The following is a description of a gene set: Blindness Human Gene Set: HP_BLINDNESS Blindness is the condition of lacking visual perception defined as a profound reduction in visual perception. On the 6m visual acuity scale, blindness is defined as less than 3/60. On the 20ft visual acuity scale, blindness is defined as less than 20/400. On the decimal visual acuity scale, blindness is defined as less than 0.05. Blindness is typically characterized by a visual field of no greater than 10 degrees in radius around central fixation. studied in species Homo sapiens, and this is the list of marker genes: CEP19, CEP290, HPS1, ZNF513, PDHA1, NDUFS4, NDUFA6, ZNF408 (zinc finger protein 408), BBS4, NDUFAF4, PDGFB, CAPN5, B3GALNT2, NAA10, FKTN, OPA3, AIPL1, RP1, TBC1D24, MFSD8, PPT1, HEXB (hexosaminidase subunit beta), PDE6G, FAS (NCBI Gene Id 355), GMPPB, KIF11, IDH3B, PRPS1, PIK3R2, BMP4, ATP5F1D, MT-ND3, AHI1, SLC7A14, EYS, BBIP1, CLN3 (CLN3 lysosomal/endosomal transmembrane protein, battenin), PRPF8, NDUFV2, CLRN1, BBS10, POGZ, ABCD1, ARL6, COX7B, PRCD, PDE6A, ROM1, CNGB1, FREM2, CDH23, KIF14, IL12A, AKT1, AIP, LARGE1, CREBBP, CFAP418, NEK2, IDH3A, SARDH, RBMX, SMO, MERTK, CNGA1, PEX6, TMEM216, NDUFS8, B4GAT1, CCR1, NDUFAF5, NF2, C4A, FLVCR1, TLR4, CRX, CTNS, PRPF6, RBP3, SDHAF1, TIMP3, SDCCAG8, HCCS, BEST1, GUCA1B, SREBF1, NDUFB10, NDUFAF1, PROM1, ERCC4, FZD4, CERKL, ITGA2B, TSPAN12, PLA2G6, RLBP1, GATA1, CC2D2A, TMEM126B, GP1BA, CA4 (carbonic anhydrase 4), BBS12, KLHL7, NR2E3, MEN1, NDUFB3, PCARE, KIAA1549, LRP5, GJB2, HEXA, PLOD1 (NCBI Gene Id 5351), NLRP3, LRAT, OFD1 (OFD1 centriole and centriolar satellite protein), ARNT2, MT-ATP6, PRPF4, TMEM138, GNAQ, AGBL5, TULP1, UROD, ATP5F1E, RDH12, IMPDH1, TOPORS, PRPF3, NDUFS7, PSAP, SCLT1, OAT, ASNS, NDUFAF8, BBS9, BBS1, MTR, GNAS, ALMS1, KLRC4, NDUFAF2, FBN1, RP9, IFNGR1, EIF4A2, FDXR, TNFSF11, SDHA, EIF2B1 (NCBI Gene Id 1967), UROS, IFT74, MKKS, NDUFS3, FKRP, ATOH7, USH2A, NDUFV1, HGSNAT, KIZ, HSD17B10, SMCHD1, ITGB3, IMPG2, CEP164, FAM161A, FOXRED1, TERT, ATRX, ARL3, SUFU, SMARCE1, CRB1, BCOR (NCBI Gene Id 57686), CDH3, ATXN7, NDUFS1, RGR, ATIC, ATP5MK, ACTB, STAT4, SAG, POLG, GP1BB, BTNL2, ATP1A3, IFT88, IL12A-AS1, NF1, SEMA4A, PANK2, DHDDS, BBS7, RP2, TTC8 (NCBI Gene Id 123016), PIK3CA, PRPH2, LONP1, TIMMDC1, MTRR, SCN1A, MEFV, ITGA2, MKS1, TUB, CTC1, PITX3, HLA-DRB1, UBAC2 (NCBI Gene Id 94902), SDHB, NDUFB11, SPATA7, NUBPL, MT-ATP8, ATPAF2 (ATP synthase mitochondrial F1 complex assembly factor 2), PQBP1, NDUFB9, NDUFS2, HLA-B, NDUFAF3, NSMCE2 (NSE2 (MMS21) homolog, SMC5-SMC6 complex SUMO ligase), CLCN7, IFT172 (intraflagellar transport 172), RPE65, BBS5, RPGR, IMPG1, ERAP1, CYP4V2, NRL, ABCA4, NDE1, TCIRG1, MT-ND2, REEP6, IL23R, ADAMTS10, ATP5F1A, FRAS1, TMEM67, BAP1, FSCN2, DHX37, PLG, BBS2, GRIP1, RP1L1, MAK, IL10, SCAPER, POMT1, ARHGEF18, CTNNB1, CD109, ASPA, NDUFA11, MTTP, UFM1, TRIM32 (NCBI Gene Id 3971), GLB1, LAMB2, TMEM231, IFT27, POMK, RNU4-2, COL2A1, PDE6B, CDHR1, GALC, IFT140, PROS1, ZNF423, WDPCP, LZTFL1, ARL2BP, PGK1, XRCC4, GM2A, GUCY2D, SMARCB1, NPHP1, AHR, POMGNT1, SDHD, MT-ND1, TRAF7, POMT2, NDUFS6, NDUFA1, RHO, PRPF31, RD3, TMEM237, NDP, SNRNP200, OPA1, DHX38